The following is a description of a gene set: Chorioretinal degeneration Human Gene Set: HP_CHORIORETINAL_DEGENERATION species: Homo sapiens, and this is the list of marker genes: GUCA1A, SAG, PNPLA6, EFEMP1, OAT, CYP4V2, DPP6, CTNNB1, HMX1, COL8A2, CFI, TSPAN12 (tetraspanin 12), FZD4, RNU7-1, JAG1, RPGRIP1, CRB1 (NCBI Gene Id 6107), CRX, CHM, PRPH2, C1QTNF5, ROM1, POU3F4, FSCN2, ADAMTS18, COL9A1, ZNF408, SPATA7, GUCY2D, CFH, TEAD1, VSX1, COL18A1, EYS, PAX2, ACVRL1, NDP, NDE1, GRHL2, VCAN, HADHA, SLC25A15, RPE65, KRAS, RP2, OVOL2, LCA5, CLCN2, CDH3, LRAT, LRP5, ZEB1, TIMP3, NRL